Given this list of marker genes COL5A1, FN1, VTN, TGFBI, CD14, COL4A6 (collagen type IV alpha 6 chain), ITGA6, NID1, LAMA5, COL11A2, ITGB1, ITGA3, COL4A4, LAMA1, LAMC2, COL4A1, PLAUR, ITGA1, LAMB2, IGSF8, COL4A3, ITGA9, COL18A1, LAMC1, THBS1, JAM2 (NCBI Gene Id 58494), VCAM1, TNC, COL6A3, ITGA4, CD81, LAMA2, ITGA10, MDK, FBN1, ITGA2, COL3A1, ITGA11, COL1A2, LAMB3, COL1A1, LAMB1, COL5A2, FGA, CSPG4, ITGAV, COL11A1, F13A1, COL7A1, VEGFA, COL6A1, COL2A1, LAMA3, SPP1, FGB, ITGA8, THBS2, TGM2, COL4A5, LAMA4, ITGA7, NPNT, COL6A2, ITGA5, FGG, PLAU, here is a description of the gene set: Human Gene Set: PID_INTEGRIN1_PATHWAY studied in species Homo sapiens Beta1 integrin cell surface interactions from publication Schaefer CF, Anthony K, Krupa S, Buchoff J, Day M, Hannay T, Buetow KH (PMID 18832364)